Given this list of marker genes Opn1mw, Rrh, Opn5, Rgr (NCBI Gene Id 57811), Gpr52, Opn1sw, Opn3, Opn4, Rho, Gpr88, here is a description of the gene set: Mouse Gene Set: GOMF_G_PROTEIN_COUPLED_PHOTORECEPTOR_ACTIVITY species: Mus musculus Combining with incidental electromagnetic radiation, particularly visible light, and transmitting the signal across the membrane by activating an associated G-protein; promotes the exchange of GDP for GTP on the alpha subunit of a heterotrimeric G-protein complex.